Given this list of marker genes ELOVL2, HSD17B12, ELOVL1, ACSL6, ELOVL5, ACSL1, ELOVL6, FAR1, ELOVL7, HACD1, ACSL4, DGAT2, ACSL5, ACSBG1, ACSF3, TECR, ACOT7, ELOVL4, FAR2, ELOVL3, THEM5, DGAT1, ACSBG2, HACD2, ACSL3, here is a description of the gene set: Human Gene Set: GOBP_LONG_CHAIN_FATTY_ACYL_COA_METABOLIC_PROCESS studied in species Homo sapiens The chemical reactions and pathways involving long-chain fatty-acyl-CoAs, any derivative of coenzyme A in which the sulfhydryl group is in a thioester linkage with a long-chain fatty-acyl group. A long-chain fatty acid has an aliphatic tail containing 13 to 22 carbons.